Given this list of marker genes KIT, here is a description of the gene set: part of: Drug resistance of KIT mutants Dasatinib is a type II tyrosine kinase inhibitor that is active against KIT receptors with mutations in the juxtamembrane and activation loop domains, but shows only partial activity against KIT receptors with mutations at residue V654. studied in species Homo sapiens Reactome Pathway: Dasatinib-resistant KIT mutants